Given this list of marker genes SMAD3, ETV3, SP7, DROSHA, SMAD1, POT1, SMAD5, AKAP8L, here is a description of the gene set: Human Gene Set: GOMF_DEAD_H_BOX_RNA_HELICASE_BINDING studied in species Homo sapiens Binding to a DEAD/H-box RNA helicase.